Given this list of marker genes TUBAL3, GJA5, TUBB2B, GJB2, GJA8, GJB5, CLTA (clathrin light chain A), GJA10, CLTC, GJD2, GJA4, TUBB4A, GJD4, TUBB8B, GJC2, GJB6, GJB7, TUBB1 (NCBI Gene Id 81027), TUBA3D, ACTB, ACTG1, E, DNM2, GJB3, GJC1, MYO6, TUBB6, TUBA3E, TUBA8, GJB1, TUBB8, SRC, TUBA4A, TUBA1B, CLTCL1 (NCBI Gene Id 8218), DNM1, GJA9, TUBA1A, TUBB4B, TJP1, GJB4, CLTB, AP2M1, GJA1, TUBB2A, TUBA1C, DAB2, TUBA4B, GJA3, TUBA3C, GJD3, TUBB3, here is a description of the gene set: studied in species Homo sapiens Gap junctions are clusters of intercellular channels connecting adjacent cells and permitting the direct exchange of ions and small molecules between cells. These channels are composed of two hemichannels, or connexons, one located on each of the two neighboring cells. Each connexon is composed of 6 trans-membrane protein subunits of the connexin (Cx) family. A gap of approximately 3 nm remains between the adjacent cell membranes, but two connexons interact and dock head-to-head in the extra-cellular space forming a tightly sealed, double-membrane intercellular channel (see Segretain and Falk, 2004). The activity of these intercellular channels is regulated, particularly by intramolecular modifications such as phosphorylation which appears to regulate connexin turnover, gap junction assembly and the opening and closure (gating) of gap junction channels. Reactome Pathway: Gap junction trafficking and regulation part of: Membrane Trafficking